The following is a description of a gene set: Mouse Gene Set: GOBP_NEURAL_TUBE_PATTERNING The regionalization process that regulates the coordinated growth that establishes the non-random spatial arrangement of the neural tube. species: Mus musculus, and this is the list of marker genes: Foxa1, Mnx1, Hes3, Pax6, Gli3, Rpgrip1l, Gli2, Psen1, Ift122, Ift140, Pax7, Prkaca, Wnt1, Gas1, Arl13b, Bmi1, Tctn1, Rnf220, Fgf8, Gpr161, Hes1, Gbx2, Rab23, Kif3a, Gorab, Mks1, En1, Cplane2, Tbc1d32, Cdk20, Wnt3a, Psen2, Foxa2, Kdm2b (NCBI Gene Id 30841), Bmp4, Prkacb, Ptch1, Dzip1l, Sox17, Atp6ap2, Tmed2, Smo, Gsc, Shh, Ssbp3, Wdr19, Traf3ip1, Fkbp8, Lrp6, Tmem107, Sufu, Tulp3